Given this list of marker genes SUB1, SLC25A3, HMBS, CRYZL1, RPL5, PDE4DIP, PAX4, CTSD, ERP44 (NCBI Gene Id 23071), SUGT1, ZNG1A, PAX3, OGN, WIPI2, PTCD2, KPTN, PPP2R3C, PHF6, RND2, DDX50, PEX11A, RNF19A, MGAT4A, PRDM5, DYNLT3, RAP1GDS1, RHEB, ODF2L, KPNA6, CHKA, MRPL32, ZFAND5 (zinc finger AN1-type containing 5), CHCHD5, ITGA5 (integrin subunit alpha 5), MICU2, CEMIP2, AHI1, POLB, CHIC2, PPP1R15B, SNX1, CMPK1, SRGAP2, SIGIRR, PPP1R2, GDI2, DUSP16, SNX6 (NCBI Gene Id 58533), MSL3, UHMK1, GOLIM4, MTFMT, HAUS2, EID3, CEP192, RBM28, POGK, CTDNEP1, TMA7, LIMS1, UBE2J1, CHMP5, CCDC18, BIVM, AIF1, FGD6, RAB28, PTPN23, IGSF9B, CDH18 (NCBI Gene Id 64404), EIF2S1, ABHD10, CPTP, EIF5, DHX29, CCDC122, PPP2R2A, FGGY, NCAM2, EXOC3, MRS2 (NCBI Gene Id 63855), AGA, UBE2A, DNAJB6, SUMO1, CIBAR1, MFSD6, CPEB2 (NCBI Gene Id 285549), DYNC1LI1 (NCBI Gene Id 51143), FAM161A, ARCN1, CCNH, GSPT2, HYLS1, SDHAF3, ZCCHC8, PRRT3, EXOC6B, TBC1D2, SKA2P1, UBE2N, FLG2, TCF4, MGAT2, SARNP, NFYA, MAN1B1, DOC2B, LY96, ACACA, CDC14A, LARP1B, TMEM170B, NGRN, GTF2E2, USP1, MMD, ASAH1, SDF4, TFDP2, FOXO3, RNF4, OGFOD1, RNF11 (ring finger protein 11), NAE1, HMGCS1, OTUD6A, VPS33B, PANK1, TXNDC11, ATL3, KLF8, CASP2, ATP5MK, FAF2, ACER3, SRBD1 (NCBI Gene Id 55133), here is a description of the gene set: species: Homo sapiens Cytoplasmic DNA triggers the activation of the innate immune system. While downstream signaling components have been characterized, the DNA sensing components remain largely elusive. We performed a systematic proteomics screen for proteins that associate with DNA, traversed to a screen for IFN-β-induced transcripts. We identified DSIRE (DNA sensor for the IL-1β response, previously called AIM2) as a candidate cytoplasmic sensor. DSIRE showed a marked selectivity for double-stranded DNA. DSIRE can recruit the inflammasome adaptor ASC and gets redistributed to ASC speckles upon coexpression of ASC. RNAi-mediated reduction of DSIRE expression led to an impairment in IL-1β maturation. Reconstitution of unresponsive cells with DSIRE, ASC, caspase 1 and IL-1β showed that DSIRE is sufficient for inflammasome activation. Overall, our data strongly suggest that DSIRE is a cytoplasmic DNA sensor for the inflammasome. Genes down-regulated in NIH3T3 cells (fibroblast): control versus stimulated with IFN-b. from publication Bürckstümmer T, Baumann C, Blüml S, Dixit E, Dürnberger G, Jahn H, Planyavsky M, Bilban M, Colinge J, Bennett KL, Superti-Furga G (PMID 19158679) Human Gene Set: GSE14413_UNSTIM_VS_IFNB_STIM_NIH3T3_CELLS_DN